Given this list of marker genes MUC7, SCGB3A2, HNMT, CCL11, ALOX5, IL13, TNF, HLA-G, here is a description of the gene set: An increased sensitivity of the airways to an inhaled constrictor agonist, a steeper slope of the dose-response curve, and a greater maximal response to the agonist. Human Gene Set: HP_AIRWAY_HYPERRESPONSIVENESS Airway hyperresponsiveness species: Homo sapiens